The following is a description of a gene set: Human Gene Set: GSE21379_WT_VS_SAP_KO_CD4_TCELL_DN studied in species Homo sapiens CD4 T cell help is critical for both the generation and maintenance of germinal centers, and T follicular helper (TFH) cells are the CD4 T cell subset required for this process. SAP (SH2D1A) expression in CD4 T cells is essential for germinal center development. However, SAP-deficient mice have only a moderate defect in TFH differentiation as defined by common TFH surface markers. CXCR5+ TFH cells are found within the germinal center as well as along the boundary regions of T/B cell zones. Here we show that germinal center associated T cells (GC TFH) can be identified by their co-expression of CXCR5 and the GL7 epitope, allowing for phenotypic and functional analysis of TFH and GC TFH populations. Here we show GC TFH are a functionally discrete subset of further polarized TFH cells, with enhanced B cell help capacity and a specialized ability to produce IL-4 in a TH2-independent manner. Strikingly, SAP-deficient mice have an absence of the GC TFH subset and SAP- TFH are defective in IL-4 and IL-21 production. We further demonstrate that SLAM (Slamf1, CD150), a surface receptor that utilizes SAP signaling, is specifically required for IL-4 production by GC TFH. GC TFH cells require IL-4 and IL-21 production for optimal help to B cells. These data illustrate complexities of SAP-dependent SLAM family receptor signaling, revealing a prominent role for SLAM receptor ligation in IL-4 production by germinal center CD4 T cells but not in TFH and GC TFH differentiation. Genes down-regulated in CD4 non-follicular helper T cells: wildtype versus SH2D1A knockout. from publication Yusuf I, Kageyama R, Monticelli L, Johnston RJ, Ditoro D, Hansen K, Barnett B, Crotty S (PMID 20525889), and this is the list of marker genes: SAPCD2, GMEB2 (NCBI Gene Id 26205), PLK1, IKZF3, CPLX2, P2RX3, DPP4, TTLL11, SLAMF6, ETHE1, SRPK3, HERPUD1, IRS1, FCRLA, MIS18BP1, HMGCLL1, C6orf118, N4BP2, FBXO5, CD22, TMEM263, LEF1, TRIM11, EDARADD, SYVN1, POU2AF1, CD38, CDKN2C, LAMC1, GFRA2, ID3, CAPSL, CDKN3, ARPC5L, DENND5B, SIT1, DYRK2, NIBAN3, CD79A, HDDC3, SMTNL2, SLC12A3, ENPP6, ZBTB2, ELL3 (elongation factor for RNA polymerase II 3), SPIB, CDC25B, PPP1R16B, FGF13, QSER1, RAB3IP, EBF1, SEMA3G, DESI1, SELENOM, GFRA1, WDR11, TMCC1 (transmembrane and coiled-coil domain family 1), RRM2B, VPREB3, INPP5A, RRAS2, PRR15, SCN4B, GMEB1, SGK1, GIMAP4, PIMREG, RPL3L, STEAP4, SPC25, PCMTD1, IRF4, DDC, ARL6IP1, HES1, SGO2, QRSL1, GPD1L, FRG1, SMTN, GSTT2 (glutathione S-transferase theta 2 (gene/pseudogene)), CCNB1IP1, CACNA2D1, RSPH9, RHOA, CTNNAL1, MSH5, NEU1, NUAK1, ARPP21, RPS6KB2, BST1, GPAT3, GRAP, MAGI3, BTBD10, LMNB2, PPM1E, RRAGD, TMEM131L, CCND3, LIG4, MAF, SLC37A2, CBLB, CEACAM21, RCAN2, PXK, RAG1, IL33, BCL7A, CAT, RAD51C, CHD7, MZB1, ATG16L2, CAMK1G, AKAP5, DOK3, FBXL14, FBXL12, BMAL1, MOB4, KLHDC4, DLX1, AFG2B, SOCS2, PLPP3, GPAM, PBK, GAS7, CHORDC1, BLNK, FAM53B, MREG, KANSL1L, SERTAD4, KIF23, HIVEP2, CAMK2D, LY6D, NDE1, TIFA, RAG2 (NCBI Gene Id 5897), CECR2, NCAPD2, DIP2C (NCBI Gene Id 22982), UCP2, PRKCB, ELK4 (ETS transcription factor ELK4), PRR11, ENPEP, SECISBP2L, KCTD20, RC3H1, TEDC1, SHB, RXFP1, BAZ2A, HIVEP3, C19orf38, MYBPC2, UHRF1, CCDC38, ALDH3B1, SLC15A3, ELOF1, TTF1, EIF2AK3, TNFRSF19, PKIG, CMC2, TNFAIP3, ACP3, PDS5B, UBL5, NABP1, EFHD1, FOXO1, PARPBP (NCBI Gene Id 55010), MEN1, IGLL1, DCK, FRYL, E2F2 (E2F transcription factor 2), PTTG1, CDKN2D, COLCA1, GTSE1, CENPF, SLAMF7, BCAT1, VEGFA, CPM, MINDY2, DYNC2H1, ATP1B1, TMEM255A (transmembrane protein 255A)